The following is a description of a gene set: species: Homo sapiens RA biosynthesis pathway Human Gene Set: REACTOME_RA_BIOSYNTHESIS_PATHWAY, and this is the list of marker genes: ALDH8A1, CYP26C1, AKR1C3, ALDH1A3, RDH10, RDH16, ALDH1A1, SDR16C5, ADH1A, RDH13, DHRS3, RDH14, CYP26B1, DHRS9, ALDH1A2, RDH5, RDH11, ADH4, DHRS4, CYP26A1, CRABP1, ADH1C